Given this list of marker genes KDELR3, ARF1, TMED2, KDELR2, ARCN1, TMED1, TMED7, TMED3, COPB1, COPE, GBF1, TMED5, COPG2, KDELR1, TMED6, COPG1, TMED10, TMED4, COPZ2, COPA (NCBI Gene Id 1314), COPZ1, COPB2, TMED9, here is a description of the gene set: Human Gene Set: KEGG_MEDICUS_REFERENCE_COPI_VESICLE_FORMATION Pathway Definition from KEGG: GBF1 -> ARF1 == (KDELR+TMED2+TMED10) == (COPI+TMED4/9+TMED1/3/5/6/7) species: Homo sapiens COPI vesicle formation. Pathway ID: N01293. Pathway type: Reference. Pathway class: nt06125 Membrane trafficking (bacteria).